Given this list of marker genes KCNK4 (potassium two pore domain channel subfamily K member 4), GRIK2, ADORA1, OPN4, SCN11A, EPHB1, NTRK1, HTR2A, OPRK1, LXN, CXCL12, WDR47, ANO1, COMT, ASIC3, NTSR1, BTBD9, TRPM8, TAC1, PRDM12, NR2F6, SCN9A, TRPA1, DISC1, SCRN3, TRPV1, MMP24, RHO, TAC4, ADRA2A, here is a description of the gene set: species: Homo sapiens Human Gene Set: GOBP_SENSORY_PERCEPTION_OF_TEMPERATURE_STIMULUS The series of events required for an organism to receive a sensory temperature stimulus, convert it to a molecular signal, and recognize and characterize the signal. This is a neurological process.